The following is a description of a gene set: Bcl6 germline deletion causes a prominent inflammatory disease, owing to over-expression of Th2 cytokines, and affects the properties of B cells prior to immunization. Therefore we established the B cell-specific Bcl6 deletion mice and analyze the gene expression of naive B cells under physiological conditions. Human Gene Set: GSE28737_BCL6_HET_VS_BCL6_KO_MARGINAL_ZONE_BCELL_UP Genes up-regulated in marginal zone B lymphocytes with knockout of BCL6: heterozygous versus homozygous. studied in species Homo sapiens from publication Kaji T, Ishige A, Hikida M, Taka J, Hijikata A, Kubo M, Nagashima T, Takahashi Y, Kurosaki T, Okada M, Ohara O, Rajewsky K, Takemori T (PMID 23027924), and this is the list of marker genes: VSX2, FBP2, EPOR, SLC34A3 (NCBI Gene Id 142680), IL36A, PNMA8B, IFIH1, PHF21A, PDE6H, SDHA, COL27A1 (NCBI Gene Id 85301), STRA6, ALOX15, FOXN4 (forkhead box N4), SVOPL, PLEKHF2, ATP2B2, RFLNA, N4BP1, GLYCTK, ARHGAP25, ITK, GLIS3, CIMIP2A, FAM167A, FMO2, PCSK7, CXCR4, RERE, GOT1L1, TMCC3, ELL3, PTPRZ1, HELZ2, FAM178B, CD22, TEX44, IFIT1B (interferon induced protein with tetratricopeptide repeats 1B), ABCA13, ILDR1, MXD1, OPRK1, THEM5, MTOR, PLA2G2A, PCSK1, TMEM184B, MSC, NRXN2, SLC22A18, IRF2, TDRD7, CFLAR, TLR7, SLC44A4, NLRP14, TMEM171, TMEM268, BHMT2, JSRP1, GCH1, CCKBR, MOGAT2, C2CD4C, SDK2, FOXL1, ANKS1B, DLX3, DYNC1I1, HCN3, THEMIS, CEP57L1, PTTG1, NQO2, ZBTB5, DNAH5, NIPAL1, GP5, ACE2, NRBF2, PLCH2, TENT4A, CDKL3, KLK7, ANGPTL7, NPHP1, MUC16, SYNPO2, MARCO, MGST2, MYO1C, AMTN, USP25, INSM1, CLBA1, FRMD4A, AMN1, KRT75, FAP, EPCIP, MYCBP2, MSANTD1, CMPK2, IRF7, KLRK1, TTC28, FFAR4, PTGFRN, SPINK5, LIMS2, CSTA, CCDC33, SNX2, EDA (ectodysplasin A), PLPPR5, FAM131C, ST8SIA1, ARHGAP6 (Rho GTPase activating protein 6), VMP1, ATP2A1, ZUP1, CYP4F22, PRELID3A, PCDHB7, GLT6D1, CELF2, SMARCA2, KCTD7, ANKRD13B, BOC, CNKSR2, SLFN12, CRLF3, TRIP6, PHEX, GPR45, SLC46A2, LYPD6B, FBN1, DCK, ENPP4, CNR1, PCDH18, UTS2, IFFO2, SV2B, HSH2D, TCAF2 (TRPM8 channel associated factor 2), ZNF8, OAS1, DCLRE1C, AGTR1, PNISR, RNF114, PROC, STX19, ACTRT3, DCP2, KRTAP11-1, UBL5, PISD, ADAMTS6, DNAL1, HAS2, RXFP2, TMEM63C, GZMH, PI16, HTRA3, MTTP, CES4A, DUSP28, ABCB9, IRX1, BPIFB2, NID1, DBH, TET2, SLC15A4, TEC, ANGPT1, DUSP5 (NCBI Gene Id 1847), CHAD, APLP1, FRRS1L, ITM2B, ATP1A3, CA13, PRPF40A, SASS6, GJB2, TOM1L2 (target of myb1 like 2 membrane trafficking protein), LGR5, COL19A1, POLN, CXCL10, MDGA1, STAT2, CATSPERD, TIMELESS